The following is a description of a gene set: The removal of one or more ubiquitin groups from a protein. studied in species Mus musculus Mouse Gene Set: GOBP_PROTEIN_DEUBIQUITINATION, and this is the list of marker genes: Usp14, Otud7b, Usp15, Usp32, Usp3 (ubiquitin specific peptidase 3), Park7, Usp53, Usp51, Josd2, Usp8, Otub1, Yod1 (NCBI Gene Id 76190), Usp44, Usp10, Usp45, Spata2, Usp40, Zranb1, Otud6a, Vcpip1, Usp9x, Usp48, Atxn3 (ataxin 3), Dnajb2, Usp34, Shmt2, Uchl5, Tank, Usp2, Abraxas2, Otud7a, Stambpl1, Otulinl (OTU deubiquitinase with linear linkage specificity like), Usp28, Usp47, Usp24, Brcc3, Mindy3 (NCBI Gene Id 99325), Uchl3, Otud5, Otud1, Itch, Psmd14, Usp46, Usp4, Stambp, Usp9y, Usp39, Usp29, Usp37, Usp17la (ubiquitin specific peptidase 17-like A), Uchl1, Usp5, Usp27x, Vcp, Usp1, Usp54, Usp13, Usp7, Mindy4, Usp49, Usp22, Usp17lc, Uchl4, Usp18, Otub2, Bap1, Usp17ld, Usp26, Zc3h12a, Usp50, Cyld, Usp43, Usp19, Usp20, Usp33, Josd1, Usp21, Usp25, Usp36, Trim21, Usp17le (ubiquitin specific peptidase 17-like E), Otud4, Otulin, Usp42, Usp11, Usp38, Ubxn1, Brcc3dc, Tnip1, Usp12, Usp17lb, Usp30, Tnfaip3, Kdf1, Otud6b, Otud3, Usp16, Nop53